The following is a description of a gene set: Human Gene Set: GOBP_CELL_SUBSTRATE_JUNCTION_DISASSEMBLY studied in species Homo sapiens The disaggregation of a cell-substrate junction into its constituent components., and this is the list of marker genes: STON1, DUSP3, MAP4K4, PRICKLE1, ARF6, MAPRE2, PIK3R1, IQSEC1